The following is a description of a gene set: Resolution of AP sites via the multiple-nucleotide patch replacement pathway species: Mus musculus Mouse Gene Set: REACTOME_RESOLUTION_OF_AP_SITES_VIA_THE_MULTIPLE_NUCLEOTIDE_PATCH_REPLACEMENT_PATHWAY, and this is the list of marker genes: Rpa1, Pold2, Pcna, Rfc2, Parp2, Rpa2, Rfc4, Pole3, Rfc1, Lig1, Rfc3, Pold3, Apex1, Pold1, Pole, Parp1, Parg, Fen1, Polb, Pold4, Rfc5, Pole2, Rpa3 (replication protein A3), Pole4, Adprs